The following is a description of a gene set: studied in species Mus musculus Mouse Gene Set: GOBP_CELLULAR_RESPONSE_TO_LIGHT_STIMULUS Any process that results in a change in state or activity of a cell (in terms of movement, secretion, enzyme production, gene expression, etc.) as a result of a light stimulus, electromagnetic radiation of wavelengths classified as infrared, visible or ultraviolet light., and this is the list of marker genes: Kcne1, Bmf, Nlrp1b, Cops9, Aqp1, Rp1, Opn4, Opn1sw, Mc1r, Trex1, Ep300, Xpc, Pcp2, Actr5, Fbxw7, Rpgr, Mmp2, Rrh, N4bp1, Polk, Map3k20, Kdm1a, Rpl26, Gpr88, Triap1, Pola1, Gnat1 (G protein subunit alpha transducin 1), Xpa, Stk11, Ddias, Npm1, Nlrp1a, Casp9, Ruvbl2, Mapk11, Crb1 (NCBI Gene Id 338525), Cers1, Pold3 (polymerase (DNA-directed), delta 3, accessory subunit), Cul4b, Mapk13, Opn1mw, Rgr, Eif2s1, Hyal3, Rad23b, Rhbdd1, Nsmce3, Nfatc4, Bak1, Mapk14, Rad23a, Ei24, Usp28, Pik3r1, Crip1, Mapk9 (NCBI Gene Id 26420), Trp53inp1, Aurkb, Cul4a, Gpr52, Ppid, Trpm1, Ddb2, Dhx36, Akt2, Ptprk, Ercc1, Trp53, Yy1, Poli, Opn5, Pbk, Agap3, Rbx1-ps, Mme (membrane metallo endopeptidase), Prkcd, Pierce1, Mdm2, Ddb1, Grk1, Mfap4, Gnb5, Hyal1, Mettl3, Mmp1a, Sirt1, Mmp1b, Mmp3, Sde2, Cdc25a, Rgs9, Pcna, Zbtb1, Bax, Mmp9, Aipl1, Polh, Parp1 (poly (ADP-ribose) polymerase family, member 1), H2ac25, Rbx1, Slc24a4, Rho, Ino80, Noc2l, Opn3, Ercc4, Crebbp, Pold1, Atr, Nscme3l, Eif2ak4 (NCBI Gene Id 27103), Tmem161a, Rhno1, Nedd4, Timp1, Hyal2, Cdkn1a, Rnf168 (NCBI Gene Id 70238), Smpd1